Given this list of marker genes Kdm7a, Nxt2, Ak4 (adenylate kinase 4), Bcorl1 (BCL6 co-repressor-like 1), Smad9, Kcnk2, Hcn4, Pou2af3, Capza1, Fam91a1, Tmem178b, Tgfbr1, Wsb1, Amer2, Hycc2, Nusap1, Ikbip, Tmtc2, Abcb9, Ttc9, Rcor3, Syn3, Ice1, Pacc1, Paip2, Pde3a, Zfp26, Pdgfra, Nav2, Ro60, Phf6, Rnf144a, Ticam1, Cables2, Nemp1, Rps6kb1 (ribosomal protein S6 kinase, polypeptide 1), Reln (NCBI Gene Id 19699), Dtx4, Csf1, Ccdc92, Sim1, Slc8a1 (solute carrier family 8 (sodium/calcium exchanger), member 1), Crkl, Phactr4, Sema6d, Ywhab, Galnt3, Tmem64, Jag1, Bend4, Melk, Sall4, Csmd2, Ech1, Esr1, Nrk, Dot1l, Tmem121b, Nsd2, Abhd17c, Pank1, Rgl2, Plagl1, Edn3, Trim12c, Mosmo, Dpys, Eif2s2, Tril, Ube2n, Spty2d1, Arhgef40, Cecr2, Ift70a1, Klhdc8a, Rnf38, Adgrg6, Akirin1, Palld, Casc3 (exon junction complex subunit), Xpr1, Aph1a, Fam78a, Unc80, Iffo2, Tor1aip2, Ephb2, Mapk8ip3, Kcnk10, Gcc2, Cts8, Mmd, Ube2w, Neurod6, Kdm3a, Fn3krp, Stmn2, Sh3bgrl2, Ildr2, Grik3, Ankrd6, Ing5, Med12l, Dcx, Tgds, Cds1, Rngtt, Slc6a1, Ubr1, Plekhm3, Cxadr, Tbc1d22b, Krit1, Epb41l1, Slc35f1, Klrb1f, Nemp2, Kcne4, Usp42, Unc13c, Nrbf2, Gpr149, Rgs8 (regulator of G-protein signaling 8), Itsn2 (intersectin 2), Riok2, Rsbn1l, Peli2, Ppfia2, Nsd1, Pgap1, Bag2, Mcf2l, Wnk1, Fam120c, Dclre1c, Car10, Tmem240, Ppm1e, Vangl2, Osbpl2, Sec61a1, Ankrd40, Dcp2 (NCBI Gene Id 70640), Pxmp2, Frmpd3, Myt1, Ptprt, Slc35f3, Ppig, Ulk1, Stk32a, Phb1, Samd12, Zfp664, Fut9, Lrguk, Gria3, Fbxw7, Gab1, Gabra6, Erlec1 (NCBI Gene Id 66753), Atxn10, Pik3r1, Dnajc3, Itpkc, Msi2, Srek1, Szrd1, Zhx1, Limk1 (NCBI Gene Id 547389), Armc8, Ak2, Xirp2, Tbc1d8, Ppp1r3d (NCBI Gene Id 70414), Pparg, Gigyf2, Stox2, Ugt8a, Tmem170, 1700025G04Rik, Colgalt2, Zfp704, Plppr1, Tmem167, Pds5b, Scaf11, Glipr2, Rab11fip1, Hapln1, Zfp652 (zinc finger protein 652), Sertad2, Gcc1, Plk2, Ngfr, Ubr5, Ccdc88a, Ncapg2, Matn3, Phf20, Atp8a1, Sec24a, Eef1ece2, Iglon5, Met, Agfg1, Tmem25, Pcdh20, Slc39a12, Kcnn3, Mtss2, Arrdc4, Dcc, Slc10a7, Gnpnat1, Snap25, Rybp, St6galnac3, Kmt2a, Mtcl2, Gys1, Mief1, Camta1 (calmodulin binding transcription activator 1), Pira2, Mdfi, Neo1, Ltbp1, Rapgef2, Arhgap12, Fbln2, Abl2, Sdha, Dcaf7, Retreg3, Map2k7, Luc7l, Nf1, Arid1b, Vegfc, Rfxap, Lbh, Mnt, Chd2, Sh3rf1, Msl1, Ngdn, Snx12, Sirt1, H3f3b, Ncam1, Tmem170b, B3gnt7, Slc5a3, Slc22a23, Arhgap21, Kcnj3, Ece2, Diras1, Fryl, Ptpn9, Cbx5, Pdhx, Dlk1, Erich5, Isl1, Gltp, Lrat, Ttc39a, Scai, Mab21l4, Setd7, Bub1b, Kmt2c, Chtf8, Nfx1, Poglut1, Mdn1, Mtdh, Eml1, Cdip1, Strn4, Aff4, Sgcb, Rps6ka5, Ube2e2, Sp1, Magi3, Dcun1d4, Acvr1c, Pikfyve, Ppp1cc, Med14, Mapk14, Fam184a, Itga5, Usp49, Samd10, Nrep (neuronal regeneration related protein), Kctd11, Kcnd3, Dipk1a, Adamts18, Dnajc13, Grm5, Naa50, Stk40 (serine/threonine kinase 40), Usf3, Pom121, Usp46, Irs1, Pogz, Col27a1, Cox11, Anks1, Plagl2, Cpne8, Naa15, Acvr2a, Hoxa5, Pdia5, Zfp36l1, Car7, Slc7a14, Cyp39a1, Ret, Elmo1, Syt4 (synaptotagmin IV), here is a description of the gene set: from publication Chen Y, Wang X (PMID 31504780) Genes predicted to be targets of miRBase v22 microRNA mmu_miR_6539 in miRDB v6.0 with MirTarget v4 prediction scores > 80 (high confidence targets). Mouse Gene Set: MIR_6539 studied in species Mus musculus